Given this list of marker genes Cbs (NCBI Gene Id 224676), Mpst, Sp1, Cth, Ethe1, here is a description of the gene set: Mouse Gene Set: GOBP_HYDROGEN_SULFIDE_METABOLIC_PROCESS species: Mus musculus The chemical reactions and pathways involving hydrogen sulfide, H2S.